The following is a description of a gene set: Human Gene Set: GSE43955_TH0_VS_TGFB_IL6_IL23_TH17_ACT_CD4_TCELL_60H_UP from publication Yosef N, Shalek AK, Gaublomme JT, Jin H, Lee Y, Awasthi A, Wu C, Karwacz K, Xiao S, Jorgolli M, Gennert D, Satija R, Shakya A, Lu DY, Trombetta JJ, Pillai MR, Ratcliffe PJ, Coleman ML, Bix M, Tantin D, Park H, Kuchroo VK, Regev A (PMID 23467089) Genes up-regulated in CD4 T helper cells (60h): Th0 versus Th17 treated with TGFB1, IL6 and IL-23. Despite their enormous importance, the molecular circuits that control the differentiation of Th17 cells remain largely unknown. Recent studies have reconstructed regulatory networks in mammalian cells, but have focused on short-term responses and relied on perturbation approaches that cannot be applied to primary T cells. Here, we develop a systematic strategy – combining transcriptional profiling at high temporal resolution, novel computational algorithms, and innovative nanowire-based tools for performing gene perturbations in primary T cells – to derive and experimentally validate a temporal model of the dynamic regulatory network that controls Th17 differentiation. The network is arranged into two self-reinforcing and mutually antagonistic modules that either suppress or promote Th17 differentiation. The two modules contain 12 novel regulators with no previous implication in Th17 differentiation, which may be essential to maintain the appropriate balance of Th17 and other CD4+ T cell subsets. Overall, our study identifies and validates 39 regulatory factors that are embedded within a comprehensive temporal network and identifies novel drug targets and organizational principles for the differentiation of Th17 cells. studied in species Homo sapiens, and this is the list of marker genes: ACYP1, MXD3, KITLG, PLAUR, GEM, ZBTB14, GSN, ADAR, PLS3, GUSB, ZNF22, ALDH9A1, ZNF799, CHI3L1, SLC2A8, CLASRP, MTERF2, SYT17, GCOM1, SRP9, AFF4, LPL, APOE, PPY, PHLDA1 (NCBI Gene Id 22822, pleckstrin homology like domain family A member 1), YWHAH, CD300C, TUBA1C, THBS1, ADSS1, CST3, FBXW11, CLIC3, ELP3, MAP1B (NCBI Gene Id 4131, microtubule associated protein 1B), CFHR1, MGAT3, CNR1, ISG20, TSC22D3, TAGLN2, GLIPR2, MGST3, BAK1, RDH11, MSL2, OLR1, NUP50, RASSF2, PSMD8, TBC1D20, HNRNPAB, CR2, CD48, PTCH1, MKRN2, COMMD3, GRIK2, PAM, MRPS28, TRAIP, RASSF5 (NCBI Gene Id 83593), VSX2, POLB, BDNF, CDKN1C, MLEC, ATP6V1C1, CRMP1, ATP5PF, ESRP1, MAP3K2, IL15RA, FAM83G (family with sequence similarity 83 member G), INTS7, MBP, PCGF5, CAV1, PTGIS, DOCK7, ACADL, CACNB3, BCKDHB, DENND4C, ST6GALNAC4, MRPL48, SCAF11, PRNP, ARL5A, ATP6V1A, HTR5A, BGN, IVD, RYK, CHRNA6, CEP350, RCAN1 (NCBI Gene Id 1827), EPHA5, BHLHE40, CREB1, EVL, CSNK2B, TNFSF9, C9orf40, TMEM176A, RTN4, GSTK1, SLC22A6, MFGE8, MYH14, GJC1, TNNI2, RCN2, DPH5, S100A14, POR, C1R, PTPRJ, PFKFB2, F11R, BSN, HDAC6, CFAP68, STXBP1, CCN2, PDIA3, PDE6B, CMPK2, SFN, IL12RB2, MFSD14B, PAN2, RNH1, PCSK6, PROCR, ERCC1, CCL5, PNOC (NCBI Gene Id 5368), DDOST, CCN1, RBCK1, C1QB, DEAF1, DGAT1, CENPL, KRT6A, HIPK1, UTP4, GPN3, SART1, EYA1, FBXL15, TXNDC12, ISOC1, RRP9, DDAH2, IGFBP2 (NCBI Gene Id 3485), LEF1, LY9, GM2A, CAPZB, KRT27, SLC39A9, DNAJA1, ANTXR2, EYA2, ODC1, CTRB2, TUBA1B, IDE, SNRPD3, HPCA, PFDN2, RNF2, TAGLN, BCL2, CD5L, ERRFI1, CD81, TM7SF2, KLF6, NR4A1, ARL4D, CHAD, MXI1, PRDX1, S100A11, CD247, RUNX2, AKR1B15, COL18A1 (collagen type XVIII alpha 1 chain), PEX7, DHFR, GRWD1, TCL1A, MAP2, RNF103, RNF19A, SHD (Src homology 2 domain containing transforming protein D), ACTC1